Given this list of marker genes Sox13, Skint1, Rorc, Lck (lymphocyte protein tyrosine kinase), Scart2, Ptprc, Egr3, Gimap3, Syk, Lef1, Jag2, Gimap5, Sox4, Nckap1l, Stat5b (signal transducer and activator of transcription 5B), Ccr9, Stat5a, Gpr18, Tcf7, here is a description of the gene set: Mouse Gene Set: GOBP_GAMMA_DELTA_T_CELL_DIFFERENTIATION The process in which a relatively unspecialized hemopoietic cell acquires specialized features of a gamma-delta T cell. A gamma-delta T cell is a T cell that expresses a gamma-delta T cell receptor complex. species: Mus musculus